The following is a description of a gene set: Human Gene Set: MIR7845_5P from publication Chen Y, Wang X (PMID 31504780) Genes predicted to be targets of miRBase v22 microRNA hsa-miR-7845-5p in miRDB v6.0 with MirTarget v4 prediction scores > 80 (high confidence targets). species: Homo sapiens, and this is the list of marker genes: CCDC150, PRDM16, RABL3, SUPT3H, PURB, GPX6, SOS1, SV2C, MEF2C, HUS1, FAM83D, INPP4A, VPS45, CRELD2, FAM241A, FBXL5, CPNE5, EPHA7, TNFAIP3, GALNT16, LCORL, RASGEF1B, GABRB2, SIDT2, NPRL3, SOX4, ARHGEF3, CSMD3, GNG2, ACTR2, BCL11A, G3BP2, ZBTB4 (NCBI Gene Id 57659), TRGC1, DDX6, UBE3A, DDIT3, TTF1, CLPTM1, AIF1L, KLK4, ZFP28, USP8, PTGDR, SAR1A, TBC1D22B, CEP350, KCNK13, LRIG2, STPG1, SDHA, GASK1B, KIF18A, ITCH, TTR, ZNF365, GOLGA7, DISC1